Given this list of marker genes CHSY1, ANKRD11, ABCC9, FREM1, STAG1, RNF2, ATRX, DNMT3A, HMGB3, GATAD2B, DOCK7, HRAS, TUBGCP2, ALX3, here is a description of the gene set: species: Homo sapiens Human Gene Set: HP_ABNORMAL_SPACED_INCISORS Abnormal spaced incisors